The following is a description of a gene set: Mouse Gene Set: CUI_MONOCYTE_IL15_RESPONSE_UP from publication Cui A, Huang T, Li S, Ma A, Pérez JL, Sander C, Keskin DB, Wu CJ, Fraenkel E, Hacohen N (PMID 38057668) Genes positively differentially expressed in cell type: Monocyte upon treatment with cytokine: IL-15 in mouse lymph nodes in vivo. studied in species Mus musculus Cytokines mediate cell-cell communication in the immune system and represent important therapeutic targets. A myriad of studies have highlighted their central role in immune function, yet we lack a global view of the cellular responses of each immune cell type to each cytokine. To address this gap, the authors created the Immune Dictionary, a compendium of single-cell transcriptomic profiles of more than 17 immune cell types in response to each of 86 cytokines (>1,400 cytokine-cell type combinations) in mouse lymph nodes in vivo. A cytokine-centric view of the dictionary revealed that most cytokines induce highly cell-type-specific responses. For example, the inflammatory cytokine interleukin-1β induces distinct gene programmes in almost every cell type. A cell-type-centric view of the dictionary identified more than 66 cytokine-driven cellular polarization states across immune cell types, including previously uncharacterized states such as an interleukin-18-induced polyfunctional natural killer cell state., and this is the list of marker genes: Nampt (nicotinamide phosphoribosyltransferase), Slfn5, Mxd1 (NCBI Gene Id 17119), Zfp800, Lilrb4b, Snx18 (sorting nexin 18), Ms4a6d (membrane-spanning 4-domains, subfamily A, member 6D), Pml, App, Mndal, Tor1aip1, Ms4a4c, Zup1, Tax1bp1, Fam174a, Pnp, Usp18, Apobec3, Agfg1, Snx2, Bst1, Gbp5, Ifi203, Zyx, Noc4l, Skap2, Irf8, Sdcbp, Irf1, Snx10 (sorting nexin 10), Ptpn1, Il18rap, Taf7, Hp (haptoglobin), Lamp2, Lgals9, Ranbp2, BC031181, Isg15, Ifitm2, Srgn, Cggbp1, Clic4, Parp14, Plcb1, Calr, Slfn1, Eif2ak2, Ube2l6, Tor3a (NCBI Gene Id 30935), Jpt1, Tfec, Ifi204, Tagap, Irgm1, Zfp281, Trim30c, Cgas, Clec5a, C3, Gbp2, Ilrun, Phf11b, Samhd1, Cycs, Dnaja1, Rnd1, Rigi, Marchf5, Actg1, Slpi, Batf2, Ifitm6, Ccdc86, Rnasel, Mmp8, Msrb1, Cxcl10, Tnfrsf1a, Hif1a, Ccr1, Stx11, Ifit2, Cd44, Arid5a, Ifi207, Ube2d3, Litaf, Chil3, Gbp3, Ifi211, Trafd1, Eif1a, Gbp7, Parp9, Socs3, Dr1, Vim, Fcgr3, Fcgr1, Mx1, Ifi205, Ifi47, Plek, Nrg1, Cxcl9, Dtx3l, Xaf1, Znhit1, Fam241a, Iigp1, Ccl12, Arhgdib, Pkm, Ctsz, Gbp9, Mgst1, Slfn2, Cndp2, Gyg1, F10, Hnrnph2, Myd88, Gpr141, Ccdc25 (NCBI Gene Id 67179), Morf4l2, Fn1, Ifi206, Rtp4, Themis2, Emb, F13a1, Srsf7, Kdm6b, Atp11a, Cers6, Tpm3 (tropomyosin 3, gamma), Ncf4, Icam1, Cfp, Oasl2, Ccl2, Trim30a, Mydgf, Csf2rb2, Rap2c, Fbxl5, Ifit1, Ifi213, Atp11b, Pim1, Cd300lf, Sod2, Cd40 (NCBI Gene Id 98930), Psmb9, Rab8b, Prr13, Zbp1, Hspa5, Sting1, Csf2rb, Clec4e, Pkib, Nfkbia, Daxx, Vapa, Treml2, Dnaja2, Ccl4, Calhm6, Sell, Casp4, Irgm2, Cyrib (CYFIP related Rac1 interactor B), Rab20, Slfn9, Pdcd10, Clec2d, Snx20, Rrbp1, Stx7, Pfkp, Pde4b, Ifi35, Stat1, Tifa, Gch1, Fgl2, Slc15a3, Camk2d, Msr1, Naa25, Tspo, Etf1, Prpf38a, Sarnp, Vcan, Cd69, Tpm4, Tarm1 (T cell-interacting, activating receptor on myeloid cells 1), Tle3, Irf7, Ifi209, Prdx1, Prkx, Stxbp3, Il10ra, Ctsc, Ehd1, Cd302, Rbms1, Bnip2, Aig1, Tnfaip2, Ppa1, Acod1, Picalm, Lcp2, Csrnp1, Cd274, Igtp, Cdkn1a, Txnrd1, Rhoh, Gmfg, Socs1, Fndc3a (fibronectin type III domain containing 3A), Txn1, Gda, Stk19, Tap1, Fcgr4, Rars1